The following is a description of a gene set: studied in species Mus musculus Mouse Gene Set: WP_IL1_SIGNALING_PATHWAY IL-1 signaling pathway, and this is the list of marker genes: Irak4, Nfkbib, Tollip, Sqstm1, Plcg1, Map2k1, Capns1, Mapk3 (NCBI Gene Id 26417), Irak2, Traf6, Il1r1, Ptpn11, Il1rap, Sirpa, Chuk (NCBI Gene Id 12675), Nfkbia (NCBI Gene Id 18035), Map3k7, Akt1, Il1a, Myd88, Tab1, Capn1, Irak1, Peli1, Nfkb1, Prkcz, Il1b, Rela, Mapk8, Il1r2, Il1rn, Casp1, Elp1, Irak3, Mapk1, Map3k14, Tab2